The following is a description of a gene set: species: Mus musculus Mouse Gene Set: MIR_18A_3P Genes predicted to be targets of miRBase v22 microRNA mmu_miR_18a_3p in miRDB v6.0 with MirTarget v4 prediction scores > 80 (high confidence targets). from publication Chen Y, Wang X (PMID 31504780), and this is the list of marker genes: Cntn4 (contactin 4), Slc24a2, Mcf2l, Adcy1, Mtmr10, Sim1, Lhfpl4, Lmx1a, Nectin1, Trit1, Pvalb, Atpsckmt, Scml4, Mllt6, Gsk3a, Zfp644, Afdn, Atrn, Creb1, Anxa11, Ncoa7, Hbp1, Gata2, Fam76a, Sertad3, Dgkd, Tspan11 (NCBI Gene Id 68498), Zc3h10, Aptx, Lrtm1, Tmem38a, Ccdc136, Rnf149, Anks3, Rpl15, Gys1 (glycogen synthase 1, muscle), Rhobtb2, Rassf3, Natd1 (N-acetyltransferase domain containing 1), Matcap1, Tef, Tln2, Atf7, Dcun1d3, Ube2z, Cited2, Depdc7, Brd8, Dennd1a, Dbr1, Dennd1b (DENN domain containing 1B), Prrc2b, Sox5, Golga2, Unc80